Given this list of marker genes LRP12, RILPL1, NOTCH2NLC, RAI1, IQSEC2, DEAF1, GIPC1, FLII, MATR3, here is a description of the gene set: Human Gene Set: HP_ABNORMAL_VOCAL_CORD_MORPHOLOGY Abnormal vocal cord morphology studied in species Homo sapiens An abnormality of the vocal cord.